The following is a description of a gene set: Transport of connexons to the plasma membrane Mouse Gene Set: REACTOME_TRANSPORT_OF_CONNEXONS_TO_THE_PLASMA_MEMBRANE studied in species Mus musculus, and this is the list of marker genes: Tuba8, Tubb4a, Tuba3b, Gja1, Tuba1a, Tubb6, Tubb4b, Tuba1c, Tubal3, Tubb2a, Tuba3a, Tubb1, Tuba1b, Tubb2b, Gjb2, Tubb3, Tuba4a